The following is a description of a gene set: Human Gene Set: GOBP_REGULATION_OF_RNA_SPLICING Any process that modulates the frequency, rate or extent of RNA splicing, the process of removing sections of the primary RNA transcript to remove sequences not present in the mature form of the RNA and joining the remaining sections to form the mature form of the RNA. studied in species Homo sapiens, and this is the list of marker genes: AHNAK, SRSF8, WTAP, HNRNPH3, ZC3H10, SRSF3, NPM1, SLC38A2, DAZAP1, SUPT3H, CLK2, CCNL2, RBM4, JMJD6, BRDT, RBM5, ATXN7, SGF29, SRPK2 (SRSF protein kinase 2), KHDRBS3, SF1, QKI, HNRNPF, SRSF2, RBMY1J, RBMY1F, KHDRBS1, CELF6, PRPF19, LARP7, HOXB-AS3, ILDR1, PQBP1, FUS, TRA2A, TAF12, RBM20, TMBIM6, HNRNPL, PIK3R1, TADA3, CELF3, PTBP3, RBM8A, YTHDC1, METTL4, NUP98, SNW1, RBM3 (RNA binding motif protein 3), PUF60 (poly(U) binding splicing factor 60), RBMX, SRSF10, USP22, SLC39A5, RBM15B (RNA binding motif protein 15B), TRA2B, CLK1, CELF1, PRX, SRSF7, SRSF4, CDK11B, C1QBP, SRPK1, CWC22, PTBP1 (polypyrimidine tract binding protein 1), ILDR2, CELF2, RBM15, DDX17 (NCBI Gene Id 10521), RBPMS2, HNRNPH2, SNRNP70, RBFOX3, HMX2, RRP1B, NOVA2, RBFOX1, CLK4, TRRAP, RBM11, ARB2A, TADA2B, PTBP2, THUMPD2, SRSF1, HNRNPA1, UPF3B, CELF5, RBPMS, DYRK1A, RBM25, AKAP17A, ARGLU1, FASTK, SAP18, CELF4, ENY2, RBM47, SRSF5, ZBTB7A, ESRP1, SMU1, REST, METTL16, POLR2A, SRSF6, SON, SF3B5, ZPR1, RBMY1B, HNRNPU, RBFOX2, RBM24, RBM42, MBNL3 (muscleblind like splicing regulator 3, NCBI Gene Id 55796), ERN1, SRSF9, RPS26, SRSF12, TAF5L, SRRM4, RBM39, THRAP3, KHDRBS2, FMR1, TADA1, WDR77, SF3B3, ATXN7L3, RBM38, GRSF1, RBMY1A1, AFF2, CDK11A, RBM10, DDX5, RBM23, HNRNPLL, MYOD1, EXOSC10, TAF9, KAT2A, NOVA1, CCNL1, ZNF638 (NCBI Gene Id 27332), ACIN1, SUPT20H, RBM12, RBM22, SFSWAP, RBMY1D, MBNL2, NCL, SRRM1, ZNF326, TAF10, HNRNPK, PCBP4, UPF1, U2AF2, MBNL1, PRDX6 (peroxiredoxin 6), KAT2B, TAF6L, SUPT7L, NSRP1, RBMY1E, FAM50A, UPF3A, RBMXL1, TIA1, ESRP2, STH, NCBP1, HABP4, HNRNPH1, RNPS1, RBM12B, SETX, CLNS1A, CIRBP, CLK3, MAGOH, PRMT5, AHNAK2, RPS13 (NCBI Gene Id 6207), RBM7, HSPA1A